Given this list of marker genes Tor4a, Dgkg, Diaph1, Trim8, Rasa3, Ly6g6d, Ttll11, Fam217b, Nlrx1, Fermt3, Syne1, Plek, Gas2l1, Lmna, Slc6a4, Bmp8a, Gm13986, Gramd1c, P2ry1, Cass4, Gm32014, Rsu1, Mob1b, Nr1d1, Serpinb10, Ctla2b, Zyx, Ctla2a, Slc35d3, Ptger3, Slc14a1, Ilk, Ltb4r1, Cd9, Cd200r4, Ptpn11, F5, Txk, Cnr2, F2rl3, Mdm1, Myh9, Itgb2, Gnaz, Rap1b, Gm13431, Lims1, Syk (NCBI Gene Id 20963), 4933432K03Rik, Mob3c, Sla, Slc6a3, Il12a, Dennd2d, Cdc42ep5, Siae, Med12l, Stx11, Gp5 (NCBI Gene Id 14729), Gm14965, Rsph14, Ifi47, Adcy9, Mgmt, Gp9, Tmprss7, Gm5608 (predicted gene 5608), Thbs1, Tg, I830077J02Rik, Cd226, Prkcq, Sla2, Gm12992, Nomo1, Irag1, Gp6, Gp1bb, Treml1, Cc2d2b, Tpst2, Gm11655, Trpc6, Kcnj5, Tuba4a, Abhd11, Vwf (Von Willebrand factor), Scn1b, Pf4, H1f2, Ppif, Kcnk6, Cavin2, Bin2, Itga2b, Rab27b, Alox12 (NCBI Gene Id 11684), Rgs18 (regulator of G-protein signaling 18), Commd5, Inf2, P2rx1, Gm17749, Mpig6b, Dapp1, Pttg1ip, Gm15915, F2r, Ccdc62, Tacc1, Clec9a, Nbeal2, Crtam, Camk1, Muc13, Or2v1, Rasgrp2, Mxd1, F2rl2, Rnasek, Ciao2a, Or51a42, Gm35657, Clu, Parvb, Ubash3b, Serpinb2, Btk, R3hdm4, Nacc2, Lat (NCBI Gene Id 16797, linker for activation of T cells), Inka1, Atp2a3, Tmem40, Cyp4x1, Cxcl5, Tnfsf14, Ppbp (NCBI Gene Id 75592), Hexim1, BC016579, AI504432, H2bc4, Slain2, Itgb3, Pla2g10, Ly6g6f, Gm1720, Gp1ba, Slamf1 (signaling lymphocytic activation molecule family member 1), Tln1, Mad2l1bp, Ccdc8, Mpl, Proser2, Pkd1l3, Ppp1r3d, Tagln2, Pls1, Clec1b, Ptgir, Fbxl13, Inafm2, Nrgn (NCBI Gene Id 97578), Tubb1, Lgalsl (NCBI Gene Id 68864), Il20ra, Gltp, Daam1, Vcl, Mmrn1, Prkca, Mindy1, here is a description of the gene set: from publication Cao J, Spielmann M, Qiu X, Huang X, Ibrahim DM, Hill AJ, Zhang F, Mundlos S, Christiansen L, Steemers FJ, Trapnell C, Shendure J (PMID 30787437) Mouse Organogenesis Cell Atlas (MOCA) DE_gene_main_cluster.csv, fold.change>=1.5, qval<0.05, pval<0.05 species: Mus musculus Mouse Gene Set: DESCARTES_ORGANOGENESIS_MEGAKARYOCYTES